Given this list of marker genes ATF4, MIR19A, WNT1, MMP2, HIF1A, PINK1, SIRT1, INS, NOX1, SFPQ, FZD1, HSPB1, UBQLN1, P4HB, GATA4, GPX1, MAPK7, BAG5, CTNNB1, FBXO7, PRKN, PPIA, AKT1, NONO, PARP1, PRODH, PARK7, FBXW7, MCL1, MIR29B1, MIR195, TREM2, SOD2 (superoxide dismutase 2), PYCR1 (NCBI Gene Id 5831), MIR92A1, MIR133A1, FYN, HTRA2, SOD1, NOL3, TRAP1, IL10, FGF2, ADCY10, VNN1, NME5, NFE2L2, RACK1, here is a description of the gene set: Human Gene Set: GOBP_REGULATION_OF_OXIDATIVE_STRESS_INDUCED_INTRINSIC_APOPTOTIC_SIGNALING_PATHWAY species: Homo sapiens Any process that modulates the frequency, rate or extent of an oxidative stress-induced intrinsic apoptotic signaling pathway.